Given this list of marker genes MAOA, COMT, TOMT (transmembrane O-methyltransferase), SLC6A3, here is a description of the gene set: species: Homo sapiens The human gene SLC6A3 encodes the sodium-dependent dopamine transporter, DAT which mediates the re-uptake of dopamine from the synaptic cleft. Dopamine can then be degraded by either COMT or monoamine oxidase. part of: Neurotransmitter clearance Reactome Pathway: Dopamine clearance from the synaptic cleft